Given this list of marker genes TERF2, ACE, IL18, SIRT6, RPS6KA1, ACE2, TRAF6, ACAD9, NDUFAF2, TRAF3, MAVS, ECSIT, TERF2IP, NDFIP2, TOMM70, NLRX1, IL6, AGT, NLRP3, REN, BCS1L, STING1, NOX1 (NCBI Gene Id 27035), NFKB1, TNF, PHB1, NDUFAF1, here is a description of the gene set: SARS-CoV-2 mitochondrial chronic oxidative stress and endothelial dysfunction Human Gene Set: WP_SARSCOV2_MITOCHONDRIAL_CHRONIC_OXIDATIVE_STRESS_AND_ENDOTHELIAL_DYSFUNCTION studied in species Homo sapiens